The following is a description of a gene set: Human Gene Set: MIR6507_3P species: Homo sapiens Genes predicted to be targets of miRBase v22 microRNA hsa-miR-6507-3p in miRDB v6.0 with MirTarget v4 prediction scores > 80 (high confidence targets). from publication Chen Y, Wang X (PMID 31504780), and this is the list of marker genes: EPHB3, BMP4, UNK, WNT8B, DNAAF2, CDH2, ZNF704, MED13, RUNX1, FBXL5, GSPT1, GPR75, B4GALT6, KLHDC9, ABCD2, CBLN1, PDC, LRP12, KCNH4, SLC9B1, ABCA8, IER5L, APBA2, NUFIP2, NSFL1C, RIMS1, DNAH5 (dynein axonemal heavy chain 5), SOX9, SCOC, ENAH, ELAVL4, HSD17B13, M6PR, CRADD, SETD9, CC2D2B, TFDP1, YY2, NXPH1, PPP4R1, PIK3AP1, PSD3, MCHR2, CPD, JMJD1C, ADD3, C1orf21, ADCY3, COLCA1, GRIK1, PLPPR1, UBE2J1, CDK5, PYM1, PRP4K, TBP, DOCK8, LSM12, IPMK, PRPF40A, ING3, CPA6, FHIP1B, ZBTB41, MED13L, DIP2C, FLT3, AP3B1, MED14, SACM1L, HENMT1, SHPRH, NHEJ1 (NCBI Gene Id 79840), EIF2AK3, CCDC24, RAP1B (NCBI Gene Id 5908), ARL17A, CXXC4 (NCBI Gene Id 80319), SEC61A1, EDNRB, MYT1L, DBX2, PIP5K1B, NEFM, CCDC117, SPATS2, CLPX, DDX52, LRP4, PIK3C2B, GPR12, GUCY1A2, COX5A, BNIP2, DCX, PGM3, EBF3, RCAN3, CYP24A1, RERE, TSPYL5, GCFC2, SHMT1, OXSR1, ZDHHC15, KLHL6, GRM7, FGG, MBIP, MAIP1, NAV3, NAA50, ARHGAP28, GBF1, DCHS2, APLN, TRIM71, PPP2R2A, GABRG2, FBXW11, ARFGEF1, SUN1, DNAJB11